The following is a description of a gene set: Catalysis of an oxidation-reduction in which the oxidation state of metal ion is altered and oxygen acts as an electron acceptor. species: Mus musculus Mouse Gene Set: GOMF_OXIDOREDUCTASE_ACTIVITY_ACTING_ON_METAL_IONS_OXYGEN_AS_ACCEPTOR, and this is the list of marker genes: Cp, Heph, Fth1, Fxn, Hephl1, Ftmt